Given this list of marker genes ST6GALNAC6, IGLON5, MAPT, ZFYVE28, NLRP4, CEP20, NOVA1, CASP2, DISC1, KAAG1, RAB5B, COMMD9, DOCK9, IL24, MKRN1 (makorin ring finger protein 1), GVQW3, TEX51, KDM5C, LZTS3 (leucine zipper tumor suppressor family member 3), BMF, MEIOSIN, GOLM2, TRIM11, FAM222B, FOXP4, PAX9, SYP, EVC, ACTL7A, DDIT4, CASP14, ZC4H2, VGF (NCBI Gene Id 7425), KIAA1143, CD1C, FAP, SYN1, RGMA, KCNQ3, DHRSX, GDE1, DNAI1, ERV3-1, here is a description of the gene set: species: Homo sapiens from publication Chen Y, Wang X (PMID 31504780) Human Gene Set: MIR5194 Genes predicted to be targets of miRBase v22 microRNA hsa-miR-5194 in miRDB v6.0 with MirTarget v4 prediction scores > 80 (high confidence targets).